The following is a description of a gene set: The chemical reactions and pathways resulting in the formation of a purine nucleotide, a compound consisting of nucleoside (a purine base linked to a deoxyribose or ribose sugar) esterified with a phosphate group at either the 3' or 5'-hydroxyl group of the sugar. Mouse Gene Set: GOBP_PURINE_NUCLEOTIDE_BIOSYNTHETIC_PROCESS studied in species Mus musculus, and this is the list of marker genes: Gart, Idh2, Adcy7, Atp5f1d, Atp5pf, Adcy5, Slc25a51, Entpd1, Prkn, Atpsckmt, Ndufb1, Atp5mc3, Ndufa6, Ndufv1, Npr1 (natriuretic peptide receptor 1), Ndufa5, Nppc, Ndufs7, Atp6v1a, mt-Nd2, Sphk2, Gucy2e, Stoml2, Cox11 (cytochrome c oxidase assembly protein 11, copper chaperone, NCBI Gene Id 69802), Myc, Qprt, Nadk, Nppb (NCBI Gene Id 99970), Npr2, Haao, Rd3, Slc25a13, Il4, Nme2, Ndufa1, Guk1, Ak4, Kmo, Ndufv3, Ppara, Ak2, Slc4a7, Letmd1, Prps1l1, Stat3, Adk, Papss1, Dnajc30, Ndufa2, Nme1, mt-Atp8, mt-Nd3, Nudt2, Ndufs3, Eno1b, Atp5f1b, Dck, Nmnat3, Atp5pd, Adcy6, Sdha, Gucy2g, Atp5mg, Tgfb1, Prpsap2, Atp5me, Oas1a (NCBI Gene Id 246730), Atg5lrt, Ndufb5, Ndufc2, Gucy2f, Uqcc3, Nampt, Ndufb3, Gmpr2, Ak1, Nme3, Ndufab1, Dmac2l, Guca1b, Ndufa13, Antkmt, Trem2, Papss2, Ndufb10, Adcy3, Prps1l3, Nmnat2, Adss2, Sdhd, Parp1, Ampd2, Gucy1b1, Paics, Pth2, Nppa, Nme7, Atp5mc2, Ndufa11, Ndufa7, mt-Atp6, Ampd1, Ndufb6, Adss1, Ldhc, Ndufa10, Prps2, Gucy1a1, Prps1, Ak3, Atp5mf, Ada, Adcy9, Adcy10, Ndufs2, Adcy8, Ndufa3, Sdhc, Atp6-ps, Ampd3, Hprt1, Pnp, Ndufb9, Prpsap1, Ndufs4, Atp5f1e, Nos3, Kynu, Aldoa, Impdh2, Atp5if1, Ido1, mt-Nd1, Ldhd, Impdh2-ps, Dguok, Map2k1, Ndufa12, Adsl, Slc25a12, Sdhb, Gmpr, Ndufb2, Hnf1a, Ndufs5, Ndufc1, Aspdh, Impdh1, Ido2, Bcl2l1, Gucy2c, Mthfd1, Mthfd2l, Pfas, Adcy4, Nmrk1, Guca1a, Fam3a, G6pdx, Ndufv2, Nadk2, Ndufa9, mt-Nd4l, Adcy1, Lipa, Vcp, Nme4, Tmsb4x, Oasl2, Nmnat1, Ndufb8, Gucy2d, Nme5, Ndufa8, Afmid, Atp5po, Atp5f1c, Atp5mc1, Gmps, Eno1, Ndufs1, Ndufb11, Ppat, Adcy2, Atp5f1a, Nme6, Ndufs8, Naprt, mt-Nd4, Ndufb7, mt-Nd6, Ndufb4, mt-Nd5, Adora2b, Aprt, Nadsyn1, Nmrk2, Pid1, Atp5pb, Ndufs6, Atic